Given this list of marker genes LPIN1, MTMR2, EIF2AK3, CTSC, FIG4, TNF, TNFRSF21, TMEM98, JAM2, here is a description of the gene set: Any process that stops, prevents, or reduces the frequency, rate or extent of the formation of a myelin sheath around nerve axons. species: Homo sapiens Human Gene Set: GOBP_NEGATIVE_REGULATION_OF_MYELINATION